The following is a description of a gene set: Human Gene Set: HP_IMPAIRED_TEMPERATURE_SENSATION Impaired temperature sensation species: Homo sapiens A reduced ability to discriminate between different temperatures., and this is the list of marker genes: ATL3, PMP22, HSPB1, SIM1, PRRT2, JAG1, KRT16, TGM1, SCN1A, KRT9, HEXB, HPGD, NGF, PRDM12 (PR/SET domain 12), AEBP1, ABCA1, MAGEL2, CACNA1A, SCN9A, SPTLC1, SLCO2A1, MFN2, MPZ, RNF170, ZFHX2, NDN, SNRPN, ATP1A2, LMX1B, NTRK1, OCA2, ATL1, SPTLC2, KRT1